Given this list of marker genes Slc3a1, Ctns, Slc7a11 (solute carrier family 7 (cationic amino acid transporter, y+ system), member 11), Slc7a13, Slc1a4, Slc7a9, here is a description of the gene set: species: Mus musculus The directed movement of L-cystine (also known as dicysteine) into, out of or within a cell, or between cells, by means of some agent such as a transporter or pore. Mouse Gene Set: GOBP_L_CYSTINE_TRANSPORT